The following is a description of a gene set: Reactome Pathway: Fertilization part of: Reproduction Mammalian fertilization comprises sperm migration through the female reproductive tract, biochemical and morphological changes to sperm, and sperm-egg interaction in the oviduct. Although the broad concepts of fertilization are well defined, our understanding of the biochemical mechanisms underlying sperm-egg binding is limited. studied in species Homo sapiens, and this is the list of marker genes: CATSPER2, IZUMO3, ADAM30, SPAM1, CATSPER3, ZP1, ZP3, ZP4, KCNU1, CATSPER4 (NCBI Gene Id 378807), CATSPERG, ZP2, CD9, CATSPERD (cation channel sperm associated auxiliary subunit delta), IZUMO2, CATSPERB, IZUMO1, OVGP1, ADAM2, ADAM21, ACR, CATSPER1, B4GALT1, ADAM20, IZUMO4, HVCN1 (hydrogen voltage gated channel 1)